The following is a description of a gene set: Human Gene Set: MIR7109_5P species: Homo sapiens Genes predicted to be targets of miRBase v22 microRNA hsa-miR-7109-5p in miRDB v6.0 with MirTarget v4 prediction scores > 80 (high confidence targets). from publication Chen Y, Wang X (PMID 31504780), and this is the list of marker genes: EIF4B, SHOC2, BMF, SETBP1, METTL9, IL2RB, POFUT1, DDX17, HSF2BP, EOLA1 (endothelium and lymphocyte associated ASCH domain 1), ZNF529, DPYSL3, FXR2, ELFN2, NDST1, SERTAD2 (NCBI Gene Id 9792), ACTB (actin beta), CNKSR1, SLC39A5, ZBTB4, DAGLA, FAM120A, MYEF2, IQSEC2, SLC25A43, ZSWIM4, PTGIS, GATC, COL1A1, MED17, FOXP4, BCL7A, URM1, SLC45A3, HPCA, ARRB2, PRR12, KCNC3 (potassium voltage-gated channel subfamily C member 3), CCDC43, ZNF32, GAL3ST4, NFIC, ABHD8, CKAP4, MDK, VAMP2, PRKACA, GIMAP6, IGF2, NOVA2, N4BP2, NFIX, UBQLN4, LIMK1, ZBTB6, RBM26, MBD6, ZBTB7A, MORC1, BRPF3, MECP2, FGFBP1, ACIN1 (NCBI Gene Id 22985), CBX6, OST4, CAMLG, SPRED2, FKBP3, BAHCC1, ACTR3, IGF1R, KCNJ6, ZNF385A, RGS19, CPNE5